Given this list of marker genes P4HTM (prolyl 4-hydroxylase, transmembrane), P4HA2, P4HA3, P4HA1, P4HB, here is a description of the gene set: Human Gene Set: GOMF_PROCOLLAGEN_PROLINE_4_DIOXYGENASE_ACTIVITY species: Homo sapiens Catalysis of the reaction: procollagen L-proline + 2-oxoglutarate + O2 = procollagen trans-4-hydroxy-L-proline + succinate + CO2.